Given this list of marker genes NEURL1, BRINP1, SOX12 (SRY-box transcription factor 12), TCP11X1, SNW1, CHD7, SMAD4, ARID2, AP3B1, GABPA, LILRB1, PF4, SORL1, TCP11X2, HMGB1, IFNB1, CIB1, CDH1, SMURF1, MIR29B1 (NCBI Gene Id 407024), FSHB, PLXNB3, NRARP, KAT5, ZNF488, KAT6B, FBXO7, EZH2, RUFY3, DRAXIN, PCID2, HAP1, MTURN, SHANK3, BCL11A, SASH3, MAP3K13, SEMA4F, GAS6 (NCBI Gene Id 2621), IGF1, BMAL1, EIF6, BAD, SOX8, RARG, DROSHA, LTF, MIR21, GFI1B, SHB, NR1D1, FOXP1, NTN1, MIR181C, SMAD7, METRN, TTBK1, PIAS3, NCKAP1L, L1CAM, NPR2, H4C9, TNFRSF1A, BTG2 (NCBI Gene Id 7832), SOS2, PBRM1, OPRM1, EFNB3, IL23R, BRD1, HMGA2, DTX1, SMARCC1, AKT1, ZNF365, SEMA6C, LMOD3, HCLS1, IRF7, BGLAP (bone gamma-carboxyglutamate protein), HEY1, EVI2B, RELA, REST (NCBI Gene Id 5978), IKBKB, NUMBL, ID4, TSC22D1, MIR142 (NCBI Gene Id 406934), TLX2, FZD4, IL23A, LILRB2, MIR146A, FN1, CDC73, NIN, RHOA, CAMK2B, SPINT1, STAT1, PTN, BDNF, ZEB1, ANKRD54, SMARCD2, PAX6, CD27, GSK3A, FXR1, ROBO1, LRP4 (LDL receptor related protein 4), KIT, EDNRB (endothelin receptor type B), SMARCA2, PRXL2A, ADA, RAB7B, CDKL5, HLA-G, OLIG2, SMO, FANCA, STAT5B, YWHAH, CD101, FOXP3, MYOD1 (NCBI Gene Id 4654), FES, FOXG1, DAB1, APCS, SKIL, CLCF1, PPP1CC, GORASP1, GSX2, AMBRA1, SEMA7A (NCBI Gene Id 8482), ABCC8, KLHL25, VNN1, TNF, RASGRP1, FOXO3, INHBA, MYF5, HELT, ACTN3, CUL7, BRD2, NFKBID, MIR17HG, ROCK2, LOX, CLPTM1, SPINK5, ETV5, FCRL3, IL1RL2, B2M, ADGRA2, CHODL, ABCB1, ATXN1, CUX2, MAPT, BIN1, DLX1, PTPN6, BAIAP2, RPTOR (NCBI Gene Id 654218), DOCK7, H4C11, CFL1, LTA, JAG1, SRF, GOLGA4 (NCBI Gene Id 2803), AP3D1, TNFSF11, IL21 (interleukin 21), EGR3, ZFP36L1, DNAJB11, PTPRZ1, RASSF10, HES2, FGL2, TOB2, KLF10, IL7, NF2, SHOX2, SNAI2, IL4, GDI1, PTEN, TAOK3, CCL3, PTPRS, NGF (NCBI Gene Id 4803), TBX6, TESC, TIAM2, CCL19, UFL1, CCR2, TGM2, PTK2B, CEBPB, CD2, SOD1, PSEN1, DLX2, H4C15, FBXW7, HSF1, MED1, BMP4, MPL, KDM1A, DDRGK1, KIAA0319, NOG, FOXN1, TMEM98, IL12B, GRN, PITX3, FANCD2, SOCS1, IL10 (interleukin 10), OTP, TTPA, IRF1, TMEM131L, MCF2, IL1RAPL1, H4C1 (H4 clustered histone 1), AGER, LIF, NKX6-2, RHOH, MIR137, RNF41, SLITRK1, LIG4, ISG15, S100A10, MYSM1, CNOT4 (NCBI Gene Id 4850), ZMIZ1, OPA1, DLL3, KAT7, H4C8, MT3, E2F1, RBM15, ZC3H12A, GPR137B, PURB, ANAPC2, WDR62, ANKRD27, IL5, ANXA2, ITPKA, CDKN2A, CCL11, NF1, GPR65, BCL6, CD28, BMP7, THY1, NLRP3, ROCK1, H4C3, PIK3R6, IL12RB1, YPEL4, CTNNBIP1, BHLHE41, HSPA9, ACVR2A, MAPK14, PRKCZ, CLEC12A, CDKL3, HLA-DOA, IL17A, CARTPT, AXIN2, HLA-B, CTLA4 (cytotoxic T-lymphocyte associated protein 4), YAP1, FERD3L, PLXNB2, DAAM2, TOX, PLXNB1, SPEN, SOCS5, SIGLEC15, SH3RF1, PNP (NCBI Gene Id 4860), BNC1, LEO1, TNFAIP6, PRDM1, SHH, QKI, MIR486-1, SOS1, MYB (MYB proto-oncogene, transcription factor), JUNB, SLC30A1, EPHB2, IL36B, TGFB1, BRAF, CARD11, IHH, TFE3, MECP2, ASCL1, WNT3A, CLEC7A, KHDC3L, MACF1, ACTL6B, NOS1, LGALS3, PGLYRP2, TIAM1, HDAC9, ZNF683, SEMA5A, TRAF6, HIF1A, DCSTAMP, CDH4, OCSTAMP, DAG1, HDAC1, IFNA2, PTHLH, RAPGEF2, MAP2K2, PRUNE1, CBFB, CDK6, SEMA3G, ABL1, RC3H2, PRKCH, SOX13, PHF10, CLDN18, S1PR3, IKZF3, LDLR, IL6, PLXNC1, CAV3, IL18, F11R, MAFB, CCR1, EP300, CYLD, SLIT2, ARMCX5-GPRASP2, FSHR, SEMA3F, CSF3R, THPO, TBC1D24, PGLYRP1, RPS19, FCGR2B, CDON, RCOR1, TLR9, TSPO, FAM210B (NCBI Gene Id 81895), PLA2G3, LILRB3, GPR55, CEACAM1 (NCBI Gene Id 634), ROBO2, PDE3A, EEIG1, NFKBIZ, ACTB, SPI1, RUNX1, PAF1, MAP2 (NCBI Gene Id 4133), C1QC, RNF10, MYOG, PITHD1, CSF1, ADIPOQ, NTRK3, PRDM16, MIR221, RTN4R, HLTF, XBP1 (X-box binding protein 1), AXL, GATA2, RIPK1, IL2, DIP2B, PLAG1, ADNP, SLC4A2, CTR9, FEZF1, IFNL1, MAPK11, RELN, IDH2, TCF7, NACA, ZNF16, HOXB3, ZBTB1, RECK, SYK, NFATC4, ZDHHC21, LRRC17, NFAM1, IL34, CALCA, VEGFC, IL27, MEF2C, ZBTB16, TRPC6, SIRT2, CD4, PCM1, ULK2, PARP6 (poly(ADP-ribose) polymerase family member 6), LRRK2, ADD1, PRELID1, MAP6, APPL2, TAL1, IL7R, BATF, ABCB10, RHEB, KITLG, DISC1, TP53, EPHA7, DYNLT1, RGMA, CAPRIN2, TNFSF9, RFX3, BRD7, TCTA, RARA, CREB1, DRD2, PAFAH1B1, ARID1A, TNFRSF11A, POU4F1, RAB37, NEFL, ZNF675, ING5, MYRF, CUX1, BRD4, IL2RA, H4C4, NEDD9, CEBPA, NODAL, ZNF335, RFLNB, GRM5, SOX10, ARHGAP4, MITF, SLC9B2, ZFPM1, IFRD1 (NCBI Gene Id 95049), VSIR, ULK1, HOOK3, CERS2, PROC, CTNNB1, RIPK2, HES1, CLCN2, SOX4, P4HTM, BMP2, MEAF6, LHX2, DHX36, TRIM58, GPR37L1, SMARCB1, PPARGC1B, RNF6 (ring finger protein 6), SKIC8, FRZB, TMPRSS12, CDH5, RC3H1, SYNGAP1, GATA3, GLI3, IFNG (NCBI Gene Id 3458), ZFP36, TRPV2, CX3CL1, IL2RG, F2, TLR4 (NCBI Gene Id 7099), DLL4, NKAP, TRIB1, CR1, SCIN, CLOCK, SERPINF1, LPAR3, NRDC, NPTN, LCK, CD83, ARID1B, CASP8, RAB21, HSPA1B, TNFRSF12A (TNF receptor superfamily member 12A), TRAK2, KRAS, OBSL1, H4C6, IAPP, MIR181B1, ZAP70, TBX21, PRMT1, XRCC6 (NCBI Gene Id 94359), CXCR4 (C-X-C motif chemokine receptor 4), NOTCH2, ITGB1, SMARCA4, TGFBR2, TREM2, H4C14, TRPC5, FBXO22, GPER1, MIR222, ZBTB46, TRAK1, GPRASP3, TNFSF18, TRIM32, TYROBP, CUL4A, CRABP2, HMGB2, GPR171 (G protein-coupled receptor 171), H4C16, CXCL12, PRTG, CX3CR1, SOX11, TMEM176A, IL6ST, MIR30B, NUMB, TWF2, IL15, SLAMF8, XRCC2, PRMT6, NRP1, CAPRIN1, MAN2A1, PRMT5, CYP26B1, ASCL2, PGLYRP3, SHTN1 (shootin 1), PLXNA3, LIMK1, PRKCA, ID2 (inhibitor of DNA binding 2), HEY2, ZC3H8, PIK3R1, NKX6-1, CD80, RAC3, PPP2R3C, INPP5D, PPP1R12A, CTDSP1, MMP14, IL4I1, VCL, MYF6, UBASH3B, TNFRSF1B, HES5, DCT, NOTCH1, DICER1, DCC, METTL3, HLA-DRB1, IL4R, IL17D, RAG2 (recombination activating 2), ASPM, RGS14, CD69, PAK1, PRKDC, PRKCI, KIFAP3, PCK1, MEIS2 (NCBI Gene Id 56908), PLXND1, ETS1 (NCBI Gene Id 2113), KAT6A, LRP8, ITPKB, ZFYVE27, SMARCC2, MTOR, RTN4, LGALS9, WEE2, HAX1, L3MBTL1, DBN1, PLCB1, NDFIP1, SRRT, HOXA11, CDK5 (NCBI Gene Id 1020), CAMK4, HEYL, SMARCE1, SMARCD3, SENP1, PER2, GLUL, HOXA7, FADD, MEIS1, CD46, SFRP1, TMEM178A (transmembrane protein 178A), FSTL4, FBN1, CD74, IL1B, MAP2K1, LIN28A, MIR125B1, CTNNA1, PTPRC, RHEX, HLX, TCIM, LRP2, BTK, NFKBIA, BRPF1, HLA-DRA, PRDX2, ARNT, RB1, TLR3, WNT2, BMPR1A, PPP3CA, WNT7A, EFNA5, VSX2, MDK, HOXB8, ADAM7, FOS, SYT4, HSPA1A, RAG1, INS, NR2E1, NKX2-2, FSTL3 (NCBI Gene Id 10272), NTRK2, BTN2A2, ZFP36L2, HES6, STAT5A, TRIM46, ACIN1, IL20, SS18L1, FAXDC2 (NCBI Gene Id 91674), ACTL6A, LOXL3, LYN, PSG9, DUSP10, PROX1, HDAC2, GPR137, STK25, TRIM11, IL15RA, TP73, RNF112, SLC46A2, RAC1, TCP11, ADCY10, DMRTA2, NPPC, HDAC6, AURKA, ATOH1, IST1, AMIGO1, TMEM64, KIF14, PTPN2, STAT3, DPYSL5, GPR68, CSF3, DSCAM, POU4F2, IRF4, H4C2, ISLR2, MEGF8, TESPA1, SERPINE2, GATA1, FGF2, MME (membrane metalloendopeptidase), MYCN, FXR2, MIR145, TM4SF19, HES7, WNT5A, RUNX3, TMEM176B, ERFE, PTPRD, BMPR2, STK11, SPART, ELL3 (NCBI Gene Id 80237), RND2, TENM4, MAG, GLI2, MIR223, TNFRSF11B (TNF receptor superfamily member 11b), LEF1, CRTAM, KCNK18, TNR, SMAP1, ADAM8, SKI, SART1, STAU2, LAG3, H4C12, ANXA1, FMR1, WNT10B, CD86, MALT1, HES3, DRD3, ERBB2, RASSF2, S1PR2, SLIT1, FBXW8, HOXA9, KLF13, SEMA6D, GSK3B, JAK3, RYK, SEMA4D, INHA, PAEP, ACVR1B, BHLHE40, BRPF3, KAT2A, LDB1, MAP1B, FEZF2, XRCC5 (X-ray repair cross complementing 5), H4C13, EEF2K, RFLNA, EPHA4, BCL2, WNT3, CLEC4G, EGR2, MYC, DLL1 (delta like canonical Notch ligand 1), LGALS1, NAP1L1, CLDN5, H4C5 (H4 clustered histone 5), VEGFA, HMGB3, YTHDF2, FZD3, SPP1, VAX1, LILRB4, FGF13, KCTD11, ZEB2, ZBTB7B, FOXJ1, GFAP, SLC7A5, TNFSF4, HOXA5, SMARCD1, here is a description of the gene set: studied in species Homo sapiens Any process that modulates the rate, frequency or extent of the progression of the cell over time, from its formation to the mature structure. Cell development does not include the steps involved in committing a cell to a specific fate. Human Gene Set: GOBP_REGULATION_OF_CELL_DEVELOPMENT